The following is a description of a gene set: species: Mus musculus Mouse Gene Set: GOBP_T_CELL_APOPTOTIC_PROCESS Any apoptotic process in a T cell, a type of lymphocyte whose defining characteristic is the expression of a T cell receptor complex., and this is the list of marker genes: Prelid1, Lmbr1l, Fasl, Gpam (NCBI Gene Id 14732), Wnt5a, Bcl11b, Slc46a2, Adam8, Pip, Gli3, Vhl, Rorc, Lgals3, Kdelr1, Trp53, Prkd2, Ebf4, Rps6, Ptcra, Pdcd1 (NCBI Gene Id 18566), Akt1, St3gal1, Dnaja3, Prkcq, Rag1, Jak3, Dock8, Perp, Siglec1, Serpinb9, Hif1a, Dffa, Cd27, P2rx7, Il2ra, Ripk3, Ccl5, Kifap3, Bcl3, Bcl10, Tnfsf4 (tumor necrosis factor (ligand) superfamily, member 4), Chek2, Bax, Casp8, Ripk1, Lipa, Cd47, Efna1, Gimap8, Bak1, Blm, Tsc22d3, Tnfrsf4, Fas, Fadd (Fas associated via death domain), Zc3h8, Pdcd7, Nfkbid, Bcl2, Bcl2l11, Pnp, Tgfb2, Bmp4, Ido1, Ada, Cd274, Arg2, Siva1 (NCBI Gene Id 30954), Il7r, Bbc3